The following is a description of a gene set: from publication Krige D, Needham LA, Bawden LJ, Flores N, Farmer H, Miles LE, Stone E, Callaghan J, Chandler S, Clark VL, Kirwin-Jones P, Legris V, Owen J, Patel T, Wood S, Box G, Laber D, Odedra R, Wright A, Wood LM, Eccles SA, Bone EA, Ayscough A, Drummond AH (PMID 18701491) studied in species Homo sapiens The 'amino acid deprivation response' (AADR): genes up-regulated in HL-60 cells (acute promyelocytic leukemia, APL) after amino acid deprivation or treatment with the aminopeptidase inhibitor tosedostat (CHR-2797). CHR-2797 is a novel metalloenzyme inhibitor that is converted into a pharmacologically active acid product (CHR-79888) inside cells. CHR-79888 is a potent inhibitor of a number of intracellular aminopeptidases, including leucine aminopeptidase. CHR-2797 exerts antiproliferative effects against a range of tumor cell lines in vitro and in vivo and shows selectivity for transformed over nontransformed cells. Its antiproliferative effects are at least 300 times more potent than the prototypical aminopeptidase inhibitor, bestatin. However, the mechanism by which inhibition of these enzymes leads to proliferative changes is not understood. Gene expression microarrays were used to profile changes in mRNA expression levels in the human promyelocytic leukemia cell line HL-60 treated with CHR-2797. This analysis showed that CHR-2797 treatment induced a transcriptional response indicative of amino acid depletion, the amino acid deprivation response, which involves up-regulation of amino acid synthetic genes, transporters, and tRNA synthetases. These changes were confirmed in other leukemic cell lines sensitive to the antiproliferative effects of CHR-2797. Furthermore, CHR-2797 treatment inhibited phosphorylation of mTOR substrates and reduced protein synthesis in HL-60 cells, both also indicative of amino acid depletion. Treatment with CHR-2797 led to an increase in the concentration of intracellular small peptides, the substrates of aminopeptidases. It is suggested that aminopeptidase inhibitors, such as CHR-2797 and bestatin, deplete sensitive tumor cells of amino acids by blocking protein recycling, and this generates an antiproliferative effect. CHR-2797 is orally bioavailable and currently undergoing phase II clinical investigation in the treatment of myeloid leukemia. Human Gene Set: KRIGE_AMINO_ACID_DEPRIVATION, and this is the list of marker genes: SESN2, CEBPB, ASNS, DDIT4, PPP1R15A, MARS1, PSAT1, SLC38A2, CDKN1A, SLC7A11, SARS1, RETN, TRIB3, ATF3, CBS, CHAC1, CTH, GADD45A, FYN, ATF5, STC2, CXCL8, DDIT3, ASS1, CARS1, CLEC7A, WARS1, CCNG2, VEGFA